The following is a description of a gene set: Human Gene Set: GOBP_SERINE_FAMILY_AMINO_ACID_BIOSYNTHETIC_PROCESS The chemical reactions and pathways resulting in the formation of amino acids of the serine family, comprising cysteine, glycine, homoserine, selenocysteine and serine. species: Homo sapiens, and this is the list of marker genes: SHMT2, PHGDH, SHMT1, SERINC5 (serine incorporator 5), PSPH, CBS (NCBI Gene Id 875), CTH (cystathionine gamma-lyase), GGT1, SERINC3, HAO1 (hydroxyacid oxidase 1), AGXT2, ENSG00000274276, PSAT1, SEPHS2, SEPHS1, AGXT